Given this list of marker genes ISCU, FDX2, SLC25A37, FXN, FDXR, LYRM4, SLC25A28, HSCB, ISCA1, GLRX5, NFS1, ISCA2, FDX1, here is a description of the gene set: Iron-sulfur (Fe-S) proteins are localized in the cytosol, nucleus, and mitochondria of mammalian cells. Fe-S protein biogenesis in the mitochondrial matrix involves the iron-sulfur cluster (ISC) assembly machinery. Ferrous iron is transported across the inner mitochondrial membrane into the mitochondrial matrix by Mitoferrin-1 (SLC25A37) and Mitoferrin-2 (SLC25A28). (Mitoferrin-1 is enriched in erythroid cells while Mitoferrin-2 is ubiquitous.) Frataxin binds ferrous iron in the mitochondrial matrix. The cysteine desulfurase NFS1 in a subcomplex with ISD11 provides the sulfur by converting cyteine into alanine and forming a persulfide which is used for cluster formation on ISCU, the scaffold protein. Interaction between NFS1 and ISD11 is necessary for desulfurase activity. Frataxin binds to a complex containing NFS1, ISD11, and ISCU and is proposed to function as an iron donor to ISCU or as an allosteric switch that activates sulfur transfer and Fe-S cluster assembly. Cluster formation also involves the electron transfer chain ferredoxin reductase and ferredoxin. ISCU initially forms clusters containing 2 iron atoms and 2 sulfur atoms ( clusters). They are released by the function of HSP70-HSC20 chaperones and the monothiol glutaredoxin GLRX5 and used for assembly of proteins. Assembly of larger clusters such as clusters may involve the function of ISCA1, ISCA2, and IBA57. The clusters are transferred to apo-enzymes such as the respiratory complexes, aconitase, and lipoate synthase through dedicated targeting factors such as IND1, NFU1, and BOLA3. part of: Metabolism Reactome Pathway: Mitochondrial iron-sulfur cluster biogenesis species: Homo sapiens